Given this list of marker genes CPSF4, C2orf49, CSTF2, NUP155, NUP43, RPP21, POP5, NUP54, RPP30, NUP37, RTRAF, NUP160, TSEN15, NUP93, XPOT, TPR, NUP133, NUP88, TSEN34, NUP205, NUP62, POM121, TRNT1, RPP14, CLP1, POP1 (POP1 homolog, ribonuclease P/MRP subunit), NUP107, ELAC2, SEH1L, NUP35, NUP42, NUP188, RPPH1, NUP153, TSEN2, NUP98, RPP38, NUP50, CPSF1 (cleavage and polyadenylation specific factor 1), POP7, DDX1, NUP85, RANBP2, AAAS, POP4, SEC13, NDC1, RPP40, NUP210, RAE1, POM121C, ZBTB8OS, RTCB, FAM98B, NUP214, RPP25 (NCBI Gene Id 54913), TSEN54 (tRNA splicing endonuclease subunit 54), NUP58, RAN, here is a description of the gene set: tRNA processing in the nucleus Human Gene Set: REACTOME_TRNA_PROCESSING_IN_THE_NUCLEUS species: Homo sapiens